Given this list of marker genes XRCC6 (NCBI Gene Id 94359), TBK1, DDX41, NLRP4, MRE11, NLRC3, STING1, XRCC5, TREX1, IRF3, PRKDC, DTX4 (deltex E3 ubiquitin ligase 4), IFI16, here is a description of the gene set: TANK-binding kinase 1 (TBK1) and interferon regulatory factor 3 (IRF3) are central regulators of type-I interferon induction during bacterial or viral infection. TBK1 was found to form complexes with distinct scaffolding proteins that appeared to target TBK1 to different subcellular compartments. STING interacted with both TBK1 and IRF3. Once STING is stimulated, its C-terminus served as a signaling scaffold to recruit IRF3 anhd TBK1, which led to TBK1-dependent phosphorylation of IRF3. Phosphorylation of IRF3 promoted its dimerization and translocation to the nucleus, where it triggered the transcription of interferon stimulated genes (ISGs) (Tanaka Y and Chen ZJ 2012). studied in species Homo sapiens part of: STING mediated induction of host immune responses Reactome Pathway: IRF3-mediated induction of type I IFN